Given this list of marker genes PYCR1, KRAS, TINF2, COG7, MAP2K1, SLC25A24, ABCC6, EDAR, SYNGAP1, CFTR, ADAMTSL2, ADAMTS2, KCNJ6, PLOD1, CHD2, MRAS, PARN, LZTR1, ATP6V1E1, CDH11, BRAF, EDA, CSTA, SLC6A1, PIK3R1, ALDH18A1, COL3A1, POLR3A, COG5, AP2M1, RAF1, RIT1, PTPN11, ENPP1, GORAB, TERT, ACD, TOR1A, FGFR3 (fibroblast growth factor receptor 3), MRPS2, PTEN, NAA10, TGM5, FGFR2, DKC1, ZMPSTE24, TALDO1, TWIST2, RTEL1, H4C5 (NCBI Gene Id 8367), MAP2K2, ATP6V0A2, LMNA, ZNF469, SLC2A1, EDARADD, TBL1XR1, CAV1, NEXMIF, ALG8, C1R, LIFR, SCN1A, ELN, MED12, ATP6V1A, FBLN5, SMARCA2, here is a description of the gene set: studied in species Homo sapiens Premature skin wrinkling The presence of an increased degree of wrinkling (irregular folds and indentations) of the skin as compared with age-related norms. Human Gene Set: HP_PREMATURE_SKIN_WRINKLING